Given this list of marker genes Slc29a1, Slc29a3, Slc22a1, Slc29a2, Slc28a2, Slc22a2, Slc28a1, Slc28a3, Slc28a2b, here is a description of the gene set: studied in species Mus musculus Mouse Gene Set: GOMF_PYRIMIDINE_NUCLEOSIDE_TRANSMEMBRANE_TRANSPORTER_ACTIVITY Enables the transfer of a pyrimidine nucleoside, a pyrimidine base covalently bonded to a ribose or deoxyribose sugar from one side of a membrane to the other.